The following is a description of a gene set: species: Mus musculus Any process that decreases the rate or extent of striated muscle cell apoptotic process, a form of programmed cell death induced by external or internal signals that trigger the activity of proteolytic caspases whose actions dismantle a striated muscle cell and result in its death. Mouse Gene Set: GOBP_NEGATIVE_REGULATION_OF_STRIATED_MUSCLE_CELL_APOPTOTIC_PROCESS, and this is the list of marker genes: Hand2, Trip10, Hsf1, Nol3, Pcmt1, Atg7, Sirt5, Ghrh, Nrg1, Hey2, Mdk (midkine), Rgl2, Pdpk1, Nkx2-5, Myocd, Rapgef3, Acot1, Ilk, Hmgcr, Kifap3, Notch1, Slc25a4, Gata4, Atg5, Cflar, Sirt1, Mfn2, Nfe2l2, Hspb6, Sfrp2, Nupr1, Ppp1r10, Qki, Ambra1 (NCBI Gene Id 99255), Sirt4, Bcl2, Npm1, Jak2, Bag3, Gch1, Hspa8, Pax8